Given this list of marker genes CDKN1B, STK11, EAF2, WDR77, SERPINF1, NKX3-1, here is a description of the gene set: Human Gene Set: GOBP_NEGATIVE_REGULATION_OF_EPITHELIAL_CELL_PROLIFERATION_INVOLVED_IN_PROSTATE_GLAND_DEVELOPMENT Any process that decreases the rate, frequency or extent of epithelial cell proliferation that contributes to the progression of the prostate gland over time. studied in species Homo sapiens